The following is a description of a gene set: species: Mus musculus TP53 regulates transcription of additional cell cycle genes whose exact role in the p53 pathway remain uncertain Mouse Gene Set: REACTOME_TP53_REGULATES_TRANSCRIPTION_OF_ADDITIONAL_CELL_CYCLE_GENES_WHOSE_EXACT_ROLE_IN_THE_P53_PATHWAY_REMAIN_UNCERTAIN, and this is the list of marker genes: Plk3, Plk2, Cnot11, Cnot2, Cnot4, Cnot8, Cnot1, Cnot6l, Tnks1bp1, Cnot7, Cdc25c, Cnot10, Btg2, Cnot9 (CCR4-NOT transcription complex, subunit 9), Cenpj, Npm1, Cnot6, Cnot3